The following is a description of a gene set: Genes predicted to be targets of miRBase v22 microRNA mmu_miR_3084_5p in miRDB v6.0 with MirTarget v4 prediction scores > 80 (high confidence targets). species: Mus musculus Mouse Gene Set: MIR_3084_5P from publication Chen Y, Wang X (PMID 31504780), and this is the list of marker genes: Zfp760 (zinc finger protein 760), Siah1a, Ybx3, Sema3c, Aldh1a2, Chl1, Apbb2, Rab12, Slc7a11, Hebp1, St8sia4, Aak1, Dlx4, Zfp781b, Idi2, Ddx21, Cfap53, Plk4, Cep350, Psd3, Kif4, Dach2, Cpd, Rnf115, Zfp1008, Kmt5a, Mib2, Tpp1, Col8a1, Lhfpl6, Gria1, Ctsr, Cpne8, Irf2bp1, Zfp367, Col5a1, Rbms3, Gucy2f, Tmc8, Rlig1, Mia3, Trim33, Lce1g, Cpa4, Ank2, Map3k7, Ttpal, Mrps33 (NCBI Gene Id 14548), Erbb4, 1110059E24Rik, Ccdc73, Zfp738, Pwp1, Vdac1, Creg1, Sema3a, Zfp935, Klhl5, Reep4, Tnfsf4, Mecp2, Olfml3, Prodh2, Arl14ep (NCBI Gene Id 78770), Frmd5, Zfp955a, Serpinb13 (serine (or cysteine) peptidase inhibitor, clade B (ovalbumin), member 13), Rdh11, Lratd2, Zw10, Clec3a, Ccdc126, Zfp455 (NCBI Gene Id 218311), Atl3, Hyls1, Zfp318, Bbx, Gabrg2, Fsd1l, Hif1an, Pwwp3b, Dimt1, Vti1b, Greb1l, Dazl, Psmd7, Spopfm2, Kcnj15, Ano5, Chrnb4, Lrrc15, Zfp2, Laptm5, Stt3b, Dpy30, Lpp, Eif4g3 (NCBI Gene Id 76685), Map3k2, Igf1, Naa15, Dmtf1l, Tm6sf1, Pou3f2, Slc41a1, Zfp456 (NCBI Gene Id 408065), Sos1, Jakmip2